Given this list of marker genes IGHMBP2, GNA12, PCOLCE (procollagen C-endopeptidase enhancer), EIF6, MYO9A, ANXA7, CLASP2, PLS1, RNF169, EGFL6, CD160, STRN4, PCSK9, SERPINH1, NOP58, VCAM1, LGALS8, COCH, FZR1, P2RX6, MYO6, BAK1, RPL23A, SORL1 (sortilin related receptor 1), COL6A1, LETM2, CNGA4, GBP1, PTCD3, BLOC1S6, CENPF, UXT, RPTOR, TAGLN3, MAP1S, YBX3, ESPNL, YWHAE, HMGN1 (NCBI Gene Id 3150), ESPN, DCLRE1B, PLCB2, AP1G1, HLA-DPB1, NR0B2, PRMT7, SLC25A3, KPTN, IFNA10, RBX1, LAMB1, CDH26, LUZP1, IFNA16, FBLN5, NFE2L1, NRAS, WASF2, CEBPA, OLA1, FZD5, RAD23B, PRKAG1, ITGA3, MCTS1, ANTXR1, LTBP4, RBBP4, ABLIM3, NDUFA4, PPP5C, PIK3R5, MAP1B, SMARCB1, FCMR, WASF1, SCIN, TSPAN4, KIFAP3, HP1BP3, LASP1, CALCA (NCBI Gene Id 87044, calcitonin related polypeptide alpha), FBL, DEPDC5 (NCBI Gene Id 9681), GUCY2F, ITGB5, EIF4A3, ETF1, DNTTIP1, ERCC4, ERCC1, NOD2, YTHDF1, ITGB1, USF1, AMFR, TPM4, PIGR, MYO1G, MAIP1, ABCA1 (NCBI Gene Id 8371), KHDRBS1, H1-9P, MSH2, STRAP, ARPC5L, COL5A3, ATP1B1, FSCN2, EMP2, CAMSAP1, KCTD2, AGER, CCN5, APCS, EPS8L3, RELL2, NVL, ITGA10, CIR1, CLTA, IFT56, ITGA6, BLTP3B, TMEM147, ACVR2B, IFNB1, IFNE, USH1C, TTN, FBN1, LIPC, EDF1, CX3CL1, MTRFR, KLRC1, CPSF6, TLN1, MLKL, LRP1, PFKP, ADRB2, ANK1, SUPT6H, AP1AR, EIF5A2, NRAP, FMNL2, ITGA5, UMOD, NSF, HLA-DRB4, ITGBL1, UHMK1, ACTN3, SPTB (spectrin beta, erythrocytic), RICTOR, ING2, AMBP, PRPF6, NCKIPSD, FBLN1, USH2A, MYO5A, NID2, UNK, THY1, ITGB1BP1, ITGB2, PAFAH1B1, SLF1, TSSC4, DNAJC2, ITGAX, WDR45B, CCNF, PINX1, ADD3, MYH14, CRIPT, SF3B3, IQGAP2, SLC6A3, LIMA1, BAG4, F11R, HLA-DQA1, DAP, ARHGAP27, LEMD3, CETN3, MADCAM1, GLYR1, RBM3, SCAMP5, FCER2, HLA-DMA, DMTN, RPH3A, MUTYH, ATF1, RAC1, WRAP53, FOS, DYNC1I1, INHBA, MALSU1, KIF5B, NPAS4, KDR, HIP1R, CNTF, NF2, CDKN1B, NME4, METTL17, MSH6, NAPA, PDGFRA, HNRNPAB, CAV1, CD2BP2, PTCH1, HLA-DRB5, PRMT5, L3MBTL1, ENG, DRD1, PIM1, XRCC6, SPTBN5, CNGA2, CRB2, HMGN2, IFNA2, CHMP6, CNN2, HIP1, PRMT2, LDLRAP1, DHX29 (NCBI Gene Id 94080), IFNA4, EIF1 (eukaryotic translation initiation factor 1), SNRNP70, TWF2, MYO1E, ABL2, CAPN2 (calpain 2), EIF3K, PAFAH1B3, UQCRC1, APC, GNAI2, DYNLL1, HDAC6, FBXO5, NUMA1, BOP1, AMIGO3, CACNB2, HSP90AB1, ITGA1 (integrin subunit alpha 1), ZC3H18, CD151, TAGLN2 (NCBI Gene Id 8407), DHX34, ANK3, GFAP, EIF4H, S1PR3, CXCL12, BAG3, GTF2F1, NEXN, GNAO1, ACVR2A, EPOP, SLFN12, PTX3, SIX2, EPB41L2, ANG, FGF2, GP6, SMC3, PHAX, PIP, CAPZA3, PPARA, CTBP2, PDE6G, MTHFR, CLMN, PSMF1, ADAM23, SMARCC2, SMAD4, CD22, MYH7, MYH6, ANXA11, HDAC2, IGF1, ABI3, HLA-A, STX1A, KIF3A, COL14A1, EPB41, COG2, KBTBD13, BOK, ELK1, PPP2R2A, SACS, DAG1, GSN, HCLS1, SNRPA, CARMIL1, USP13, SIRT6, CHUK (NCBI Gene Id 1147), RELA, LETM1, WIZ, CLNK, LAMA5 (laminin subunit alpha 5), NOMO3, HNRNPU, MYH11, RAB38 (NCBI Gene Id 23682), SKIL, HCN2, FCGR1A, SCAP, TSG101, MYO1B, UQCC5, CORO6, COMP, GAS2L2, TELO2, CIITA, DZIP1, DNAJB2, SEMA7A, COL4A3, DISC1, EEFSEC, GUCY2D, NPNT, PRMT1, ERI1, PRNP, MYO19, ADM2, THRA, AVIL, CEP131, SRP9, INCA1, DSTN, SVEP1, MTA2, WASHC2C, RC3H1, FHOD3, ABLIM2, MR1, LGALS3, DAB2IP, MIR30C1, IFNA14, PSME4, ATP5IF1, SIDT2 (NCBI Gene Id 51092), CTSH, MLC1, ZC3H12A, HSPG2, NAP1L4, CETN1, CTNNA1, MARCKSL1, G3BP1 (NCBI Gene Id 10146), CPEB4, PTPRC, EIF3C, C8A, CTDP1, IGF2R, VPS16, TFRC, JAML, DMP1, GNAZ (G protein subunit alpha z), ITGAE, EMILIN1, CORO1B, CD36, EIF2S1, TLN2, COL6A2, SLC25A46, SAP30L, GNAS, NASP, IFNA6, TSSK1B, SMC1A, MYH13, H1-7, ACD, FXR1, TNKS1BP1, ZNF622, CDC20B, DDX3X, SNRPB (NCBI Gene Id 6628), MYO18A, KRT19, PSG9, FERMT2, ZNHIT6, CAPG, H1-1, ARPC1A (NCBI Gene Id 10552), BRK1, FCGR2C, RANBP2, LOX, CD47, IFIH1, ERAL1, ADAMTS8, CDKN1A, CDC42BPB, IQGAP3, SAMD14, RNF185, FCGR2A, HLA-DQA2, ITGA9, AMER1, ECPAS, CASR (calcium sensing receptor), SUPT16H, SRPRA, MBD3, FMNL1, MAFB (MAF bZIP transcription factor B), DDR2, ZNF598, BAG6, BICD2, TREX1, SLF2, SAG (S-antigen visual arrestin), NEFH, LRP8 (NCBI Gene Id 7804), C4A, SPTBN2, AFG2A, FHOD1, ITGB6, LCK, PLEC (plectin), TMEM258, WDR12, RCSD1, ZNF827, PELO, PRKN, PHF6, ADD1, CGAS, ANGPTL3, CD9, ADAM11, STAU2, FGF1, GTPBP6, PCOLCE2, DYNLL2, LTN1, FRG1, TRPM3, NRG1, VPS33B, TNNC1, ITGA2B, AP2A1, MYO1D, PDZK1, EIF1B, MSR1, CD93, MCM9, CASP8, P3H4, CCN1, GNA14, HDAC1, PLTP, MEGF10, TMEM223, MYL4, SMG6, IST1 (IST1 factor associated with ESCRT-III), WFS1, MMP13, XIRP1 (NCBI Gene Id 191580), CHD4, IL12B, RARB, PYM1 (PYM homolog 1, exon junction complex associated factor), ABCF1, ARPC1B, AFDN, MB21D2, XIRP2, ITGA2, RAD23A, FLII, MMP9, TSSK6, VPS28 (VPS28 subunit of ESCRT-I), FCER1A, CD4, LETMD1, BECN2, NAA10, NEB, SEC61A2, PRR7, PSMG4, STAB2, TTR, CFTR, CD40LG, LRRK2, IL1B, TUBA1A, HEXIM1, SMAD7, MIR9-1, ADAM9, ACTR3, SHFL, ABITRAM, CDH17, DST, HLA-DMB, SMARCA4, ICAM3, MYH10, CNN1, JAM3, PTPN2, TMEM201, TPR, CNN3, VRK1, PANX2, GTF2E2, RBP4 (retinol binding protein 4), PPP1CA, SPP1, MTIF3, BMP2K, USP14, PPP1R9B, PWWP2B, BIN1, JAM2, YTHDF3, LDLR, EDIL3, SPARC, AFG2B, NISCH, HEXB, DNAAF8, LIMD2, BCAP31, MMP14, DBNL (drebrin like), EEF2, LILRA2, ERCC5, GNB2, SMARCE1, WDR1, PEX26, USP16, APOL5, DET1, CCN6, GUCY1B1, ITGAV, SECISBP2, H1-10, KLRD1, AIF1L, TSPAN8, PTK2, MLLT10, EIF5AL1, ICAM4, PPIB, SEC61B, PWWP3A, FYN, TERF2, EPCAM, UBD, GPNMB, RNF4, JMJD6, SRP72, MYO1F, HMGN4, ATP5ME, ITGB8, UCHL5, KIF3B, TPM1, CRTAP, GNAT1, MAPT, EZH2, APPL2, MTIF2, NTSR1, AJAP1, NPM1, IFT70B, TLR2, ACTR3C, IFT70A, SSRP1 (NCBI Gene Id 6749), PRICKLE1, SELP, H1-4, MRC2, CD3E, VLDLR, ULK1, NCOR2, IFNA5, SVIL, CAPZA1, PWWP2A, XPC, NAA16, RPLP1, UBLCP1, HADHB, MARF1, MTTP, HMGN5, CNGB3, XPO5, ANK2, TERC, NID1, ARNT2, THBS1, IFNW1, UBXN1, ECM2, CXADR, CPEB2, FCGR2B, CTSS, SMARCD2, TSSK2, HMBOX1, CFL2, WASHC2A, AJUBA, CD8A, SMARCC1, IFNA17, GAS2L1, FCGR1BP, ACVR1, MYO7A, STRN3, ITGA11, FCHO1, UCHL1, ADGRG1, CD177, HLA-DPA1, MYO1H, MYH7B, P4HB, EGFR, MDM2, FLNA, CCN3, HMGB1, GARRE1, BCL10, HSPA8 (NCBI Gene Id 3312), TOP2B, SHROOM2, DLG4, C1QBP, IFNA8, PARP1 (NCBI Gene Id 142), C8B, NOMO1, NDUFAF2, TREM2, GNAI3, CCDC47, AAK1, AMOTL2, P2RX1 (purinergic receptor P2X 1), TAF7, FSCN1, RBM23, H1-5, DHX33, NOC2L (NCBI Gene Id 26155), CCN2, SNRPN, TPM2, EZH1, NDUFAB1, LMBRD1, DCTN6, ADORA2A, CPS1, PTEN, SRP68, MTOR, TNC, GCLM, JMY, APOL2, CCND1, NDUFA8, CLU, MAP3K20, GNAQ, SPAST, RIPK3, CORO2A, CORO2B, PITX2, IFNK, NEMF, MACROH2A1, SHANK1, LIN37, FMNL3, FZD4, LRPPRC, PPIH, ADAMTS13, TSSK4, CRP, PAK1, ITGB7, CDK5R1 (NCBI Gene Id 8851), CD74, RHBDD2, CETN2, MICAL1, FBXW11, GNAT2, TNXB, SESN2, DCTN2 (NCBI Gene Id 1640), EPHB1, SNCA, MARCKS, SPOCK3, RNASEL, LPL, DERL2, ACTB, ISG15, SECISBP2L, C1QTNF1, CD63, H1-6, ESM1, VTN (NCBI Gene Id 7448), NCKAP1L, PRKCA, AIF1, CSDE1, MBTD1 (mbt domain containing 1), CNGA1, FRMD5, ENO2, GFRA1, CDK5RAP2, ITGAL, CFAP100, HMGN3, ITGAM, TACO1, RUVBL2, ZFAND1, H1-3, ADSS1, LONRF2, TUBB, PLS3, MYH3, TMA16, EPHB2, AHR, GAS2, CORO1C, RIPK1, SAMTOR, CD81, LAMB2, TNN, ATM, ACVR1B, HSD17B12, TTC5 (tetratricopeptide repeat domain 5), TAPBPL, VCP, INSR, CTSL, GTSF1L, SQSTM1, PANX1, VIPAS39, ATP6V0D1, MS4A1, JCHAIN, DNAAF1, NACC2, ACTR2, CFL1, WRN, GNA15, CCDC146, FLCN, SND1, SEC61A1, TAPBP, CASP3, PAFAH1B2, GLRB (NCBI Gene Id 2743), CNGA3, GABRR1, TEPSIN, RAP1B, COTL1, NIPBL (NCBI Gene Id 25836), TULP1, ACTN2, PTPRZ1, FLNB, H1-0, ADAM15, H3-3A, CTSK, DSPP, DDB2, IFNA21, SGTA, CTTN, ITGB4, H3-3B, WASF3, GATAD2B, GNB3, EPS8L1, RNF5, IQCB1, MACF1, COLEC12, NEFL, POLDIP3, PI4K2A, FSCN3, DHX9, SPOCK2, TSNAX, RPSA, TOP1, GCLC, GAS2L3, MS4A2, VILL, ITGA7, ZNHIT1, SCARF1, B2M, AKT1, CKAP5, SLC6A4, ACTR3B, ITGA8, ITCH, ITGB3, SRC, POF1B, HLA-DRB1, ITGAD, LRRC15, SRP19, IFTAP, KCNH5, GTPBP4, PDGFA, TIMM50, MYO10, MBD2, EIF2A, NUF2, APPL1, MLLT6, CYFIP1 (NCBI Gene Id 23191), TRAF2, CIB2, SAMD1, PDX1, OXA1L, RNF135, RCC1, APOA1, MYH8, ZFP36, ANXA8 (annexin A8), MTRES1, IFNA7, NME1, MISP, TRPV4, SNX3, MICALL2, TNNI3, PPIA, SMAD3, CTNNA3, NUP58, MLH1, RNF168 (NCBI Gene Id 165918), IHH, MAP3K13, CINP, SMARCA5, SPARCL1, SLC27A5, GNB1, ARPC2, PES1, RAB29, KASH5, MED1, UPF1, ARPC3, TXNRD2, DDX5, CABIN1, ADAM2, GMFG, MMP12, GGA3, GMFB, TP53, CPEB1, TAB1, CFAP73, ATMIN, ARPC5, HABP4, ILK, CYRIB, SYNE3 (spectrin repeat containing nuclear envelope family member 3), PTPRN, SPOCK1, LCP1, MYO15A, MYO16, SFRP2, LCA5, GRIN1, LZTFL1, STOML2, MYH9, ITGA4, EZR, GPSM2, KCTD5, LILRB1, CEBPE, STRN, APP, NCLN, SCARB1, BICD1, CDC20, PPP1CC, FST, FERMT3, BIRC3, HMGA2, CDH13, VWF, DERL1, TGFBR2, CD2AP, ACTR6, H2AZ1, HLA-DQB1, PICK1, GJB6, PHPT1, RAB32, NEIL3, PKNOX2, HLA-DRB3 (major histocompatibility complex, class II, DR beta 3), RUVBL1, EIF4B, GRIA1, ADGRG6, MYH15, PIWIL1, LUM, TWF1, MYO1A, SMARCA1, DRD2, MFAP2 (NCBI Gene Id 4237), ABCC9, GNA13, STXBP3, SPTBN4, PCNA, RS1, USH1G, RAD18, GNAI1, RRAS, RAB7A, MYO18B, IGHG1, SLFN14, LILRB2, YWHAB, ACTN4, SRP54, EED, GNB4, ADAM10, HSPD1, SCFD1, CLSPN, BIRC2, GNA11, DNAI3, P3H1, ANKRD54, RACK1, RAN, MCM8, TMCO1, NCOA1, SPTBN1, MYO5C, SPATA2, HLA-DQB2, GNAT3, ARID1A, HES1, ITPRID2, GNAL, CORO1A, NEAT1, SPTA1, PEX6, TIFAB, ATP5PO, TULP2, HLA-DOB, ATG101, ICAM5, NECTIN1, RAP1A, INHA, DERL3, CD3G, ADAMTS5, HLA-DOA, LRP12, ACHE, SRRT, TULP3, UBE2S, NEBL, FN1, FCGR3A, FLT3, PTPRF, CTNNA2, ATP6V1B1, SPTAN1, RAB11FIP3, ADAM22, SLC26A5, PKM, FRRS1L, SREBF1, IQGAP1, PTN, ERMN, CFLAR, CRYAB, HLA-DRA, IFNA1 (interferon alpha 1), M6PR, CBX5 (NCBI Gene Id 23468, chromobox 5), CAV3, KATNB1, NDUFA9, DOCK2, PDGFB, THBS4, MT-CYB, DDR1 (discoidin domain receptor tyrosine kinase 1), ACVRL1, LACRT, FCGR3B, SORT1, ARPC4, MYC, UBAC1, GLI3, SLC3A1, RBM39, TGFBR1, CTSB, PODN, FAP, CD44, CNGB1, PRKAA1 (protein kinase AMP-activated catalytic subunit alpha 1), ARMH4, NOD1, ADAM17, CDKN1C, COL16A1, SLC34A1, CCBE1 (NCBI Gene Id 147372), MPRIP, GIT1, COL3A1, MPV17L2 (MPV17 mitochondrial inner membrane protein like 2), FSTL3, PSMG1, H3-5, VPS4A, TMEM70, SERBP1, ITGB1BP2, HRG, CHD1L, PQBP1, MYO7B (myosin VIIB), DNAJA3, TUB, MAP2K1, ABL1, MAPK8IP2, GPIHBP1, TBC1D7, ABCE1, TGFBR3, SHTN1, AP2B1, IBSP, IGF2, HELB, GEMIN4, CCN4, NMD3, SYK, MYH1, FMR1 (NCBI Gene Id 5421), CHADL, ICAM2, APOA2, LYN, ACTN1, SLC11A2, ICAM1, MYH4, DLGAP1, KCNIP2, CTNNAL1, MYO5B, TSHR, TRIOBP, BRD4, SHROOM1 (NCBI Gene Id 134549), PEX1, NAA15 (NCBI Gene Id 80155), PLK1, GEMIN5, ARID1B, ADRA2A, EIF5A, VPS4B, CAMSAP2, MIURF, MYO1C, TGFBI, NCK2, CAPZA2, MRRF, LARP1, APOE, AEBP1, FADD, XRCC5, KRAS, GUF1, HSP90AA1, NOMO2, DAPL1, CALR, HNRNPC, VIL1 (NCBI Gene Id 7429), EFL1, KAT6B, SNRPD1, DECR2, PPP1R42, CPEB3, MYO9B, UNG, FLNC, PMS2, S1PR2, PRPF31, SHROOM3, SUCLG2, SBDS, FCGRT, IFRD2, FCER1G, FERMT1, H1-8, PINK1, PLPP3, ADD2, ADORA1, SHROOM4, MFGE8, HLA-E, PSMG3, CAV2, TGFB1, IDE, FGR, SYNE1, TMEM131 (NCBI Gene Id 55369), SIN3A, FCAR, STAB1 (NCBI Gene Id 23166), DDB1, TBC1D5, ABLIM1, RPS3, CDH5, MTA3, NPLOC4 (NCBI Gene Id 55666), HIRA, ACTL6A, NOPCHAP1, MYH2, H1-2, ZNF593, COL5A1, H3Y1, IMPACT, HTR2A, CD226, CDCA5, ALAD, CAMSAP3, PPP1R9A, WHAMM, CARMIL2, SEC61G, PARP2, PSMD14, ADRM1, KLRC2, ATR, UTRN, SNX9, HSPA5, TPM3, here is a description of the gene set: Binding to a macromolecular complex. studied in species Homo sapiens Human Gene Set: GOMF_PROTEIN_CONTAINING_COMPLEX_BINDING